Given this list of marker genes WDR35, CCDC8, NEK1, ABCD4, DYNLT2B, COL2A1, EVC, CUL7, DYNC2I2 (NCBI Gene Id 89891), OBSL1, INTU (inturned planar cell polarity protein), DYNC2H1, CEP120, LBR, IFT81, EVC2, DYNC2LI1, here is a description of the gene set: Human Gene Set: HP_HORIZONTAL_RIBS A horizontal (flat) conformation of the ribs, the long curved bones that form the rib cage and normally progressively oblique (slanted) from ribs 1 through 9, then less slanted through rib 12. Horizontal ribs studied in species Homo sapiens